The following is a description of a gene set: Mouse Gene Set: GOCC_EXTRINSIC_COMPONENT_OF_POSTSYNAPTIC_SPECIALIZATION_MEMBRANE The component of the postsynaptic specialization membrane consisting of gene products and protein complexes that are loosely bound to one of its surfaces, but not integrated into the hydrophobic region. species: Mus musculus, and this is the list of marker genes: Akap9 (NCBI Gene Id 97235), Cyth2, Rnf10 (NCBI Gene Id 54356), Olfm1, Scrib, Dgkb, Tiam1, Nptx2, Fgf22, Dgki, Cnksr2, Olfm2